The following is a description of a gene set: The eukaryotic translation initiation factor 4F complex is composed of eIF4E, eIF4A and eIF4G; it is involved in the recognition of the mRNA cap, ATP-dependent unwinding of the 5'-terminal secondary structure and recruitment of the mRNA to the ribosome. species: Mus musculus Mouse Gene Set: GOCC_EUKARYOTIC_TRANSLATION_INITIATION_FACTOR_4F_COMPLEX, and this is the list of marker genes: Eif4e3, Otud6b, Eif4a1, Eif4g3, Eif4g1, Eif4g2, Eif4e, Eif4e1b, Eif4e2, Eif4a2